Given this list of marker genes Dazap2, Ctsc (NCBI Gene Id 13032), Cotl1, Sdcbp, Lpl, Cfp, Cybb, Klf6, Itm2b, Rgs10, Ctsa, Ctss, Ly6e, Pld4, Dab2, Clec12a (C-type lectin domain family 12, member a), Ccrl2, Fcgr2b, Stab1, H2-Aa, Ccl12, C1qc, Tmem176b, Cfl1, Ier3, Ccl9, Klf2, Adgre1, Akr1a1, Rhob, Lipa, Trem2 (triggering receptor expressed on myeloid cells 2), B2m, Fth1, Cyba, Rps29, Npc2, Cd74, Rnaset2a, Trf, Sirpa, Ctsh, Fcgr1, Actr3, Pltp, Unc93b1, C3ar1, Ccl8 (C-C motif chemokine ligand 8), Sat1, Lamp1, Ctsb, Cstb, Il1rn (interleukin 1 receptor antagonist), Tyrobp, Hmox1, Rac2, Rap1b, M6pr, Laptm5, Tmsb4x, Snx5, Ms4a6b, Cd83, Hexb, H2-K1, Alox5ap, Lilrb4a, Cd68, Rgs2, Selenop, Spi1 (NCBI Gene Id 20375), Ighm, Zfp36, Wfdc17, Coro1a, Pf4, Apoe, H2-D1, Cd52, Tpd52, Asah1, Il1b, C1qb, Ccl4, Csf1r, Blvrb, Psmb8, Ifi27l2a, Lgals3, Ctsz, Cd53 (CD53 antigen), Rgs1, Lyz2, Ftl1, Mpeg1, Clta, Plek (NCBI Gene Id 69998), Arhgdia (NCBI Gene Id 77176), Cxcl2, Lst1 (NCBI Gene Id 16988), Lcp1, Plin2 (NCBI Gene Id 99959), Snx2, Mafb, Serinc3, H2-Ab1, Arpc1b, Lgmn, Arpc2, Vamp8, Mrc1, Fcer1g, Fcrl2 (Fc receptor like 2), Cxcl16, C1qa, H2-DMb1, H2-Eb1, Ccl2, Ccl7 (C-C motif chemokine ligand 7), Calm1, Ptpn18, Ccl6, Creg1, Atp6ap2, Ms4a6d, H3f3b, Lgals3bp, Cdkn1a, Ctsd, Ly86, Capza2, Ms4a7, Psap, Ms4a6c, Bcl2a1b, Ucp2, Ifi30, Ccl3, Grn, Gm6377, Pfn1, Tlr2, Atf3, Ninj1, Rab7b, Cst3, Nfkbiz, Ier5, Fcgr3, Aif1, Cd14, H2-DMa, Actb, Mcl1, Hspa1a, Sh3bgrl3, Tmem176a, Lilrb4b, Id2, Gnai2, Ehd4, Hexa, Sdc3, Marcks, Kctd12, here is a description of the gene set: species: Mus musculus from publication Zhang L, Long W, Xu W, Chen X, Zhao X, Wu B (PMID 35669188) Table S2: Representative genes of each cell cluster Mouse Gene Set: ZHANG_UTERUS_C5_MACROPHAGE